Given this list of marker genes CACTIN, CD36, TNFAIP3, PTPN6, PTPN11, CARD8, TRIB1, PRDX2, ACOD1, LY96, LACRT (NCBI Gene Id 90070), SCIMP, LY86, MIF, DEFB114, TRIM5, LTF, CD14, LILRA2, NFKBIL1, TRAF6, CX3CL1, SIGIRR, SIRPA, CD180, CD55, BMP6 (NCBI Gene Id 7964), CARD16, SASH1, PRKCA (protein kinase C alpha), DEFB118, here is a description of the gene set: Any process that modulates the frequency, rate or extent of signaling in response to detection of lipopolysaccharide. species: Homo sapiens Human Gene Set: GOBP_REGULATION_OF_LIPOPOLYSACCHARIDE_MEDIATED_SIGNALING_PATHWAY